The following is a description of a gene set: Genes up-regulated in CD4 T cells activated by anti-CD3 and anti-CD28: IL4 (48h) versus untreated (48h). species: Homo sapiens Human Gene Set: GSE2770_IL4_ACT_VS_ACT_CD4_TCELL_48H_UP Th1 and Th2 cells arise from a common precursor cell in response to triggering through the TCR and cytokine receptors for IL-12 or IL-4. This leads to activation of complex signaling pathways, which are not known in detail. Disturbances in the balance between type 1 and type 2 responses can lead to certain immune-mediated diseases. Thus, it is important to understand how Th1 and Th2 cells are generated. To clarify the mechanisms as to how IL-12 and IL-4 induce Th1 and Th2 differentiation and how TGF-beta can inhibit this process, we have used oligonucleotide arrays to examine the early polarization of Th1 and Th2 cells in the presence and absence of TGF-beta after 0, 2, 6 and 48 hours of polarization. from publication Lund R, Aittokallio T, Nevalainen O, Lahesmaa R (PMID 14607935), and this is the list of marker genes: ATP2A2, PPP4R3B, POLR2E, GAS2L1, LZTFL1, PTPRA, MCRIP2, C3orf70, PALS1, GPR137B, MAN1A2, NDUFS4, GATAD1, SLC25A3 (solute carrier family 25 member 3), LMLN, AKAP11 (A-kinase anchoring protein 11), RNASET2, CUL2, STXBP5, TXNDC11, PTPN11, LEPROTL1, WASHC5, ACTL10, DIPK2A, MBOAT1, MAPK9, PDE8B, GPD2, FNIP2, PPFIBP2, NCOA7, ALS2, PML, GLCE, RPL24, SLC25A24, RAC1, LARP1, CCNYL1, RPP25, XBP1, PLPP6, COX6A1, OMD, UQCRC2, ARHGAP21, TEX30, SDC3, ITGA8, ACVRL1, DSEL, ABI2, ACO2, PDLIM7, HLA-E, C12orf75, SREK1, CMC1, CISD3, MEIS2, RIMOC1, SLC7A8, PRELID2, CYFIP2, CCDC158, TMEM39A, ACTN1, UQCC1, WDFY4, RNF4, GOT2, NDUFAF8, TFB2M, HSP90B1, GDF5, MRPL15, ARHGAP22, GLIPR1L1, CCR1 (C-C motif chemokine receptor 1), RTCB, GOSR1, FHIP1B, TOR1B, SLC8B1, HADH, SEPSECS, STX2, SEC63, CANX, LRRC1, CYP8B1, GMFB, FUNDC1, IARS1, MSC, ITPRIPL2, SLC1A4, AFF1, CERS5, MATN4, ALDOC, UQCRB, RIMKLA, RNF217, METTL6, RPRD1B, MRPS31, MET, ZDHHC21, FARP2, MST1, PHKA2, PPP2R2A, MEF2A, PDCD6 (programmed cell death 6), ATG16L2, ERP44, CD81, FAM162A, DDX18, PLCE1, ILDR1 (immunoglobulin like domain containing receptor 1), MTMR2, KIF2A, LGALSL, AKR1A1, HNRNPLL, RNF157, MAS1, ITFG1, TNFAIP2, SGCB, WDR26, KCNE5, PPP2R3C, NKRF, VPS37C, SYNRG, DNMBP, BMI1, FGF13, CYB5A, NAA16, AGPAT5, HAVCR1, CNIH4, CCNH, ABCE1, CPNE8, NCBP2, DNTTIP2, ZFP36L1, EIF3I, MTERF3, FXYD5, SSR3, MINDY3, DTNBP1, TRIB1, CREB3L2, ORMDL2, APIP, MEX3B, C9orf72, TTC39C, GTF2E2 (general transcription factor IIE subunit 2, NCBI Gene Id 2961), PDGFA, UBE2N, CLPP, TFAP4, GRHL3, ITGA5, SLC4A7 (NCBI Gene Id 9497), HTRA1, ZNG1B, PRDX4, MTMR10, MPZL2, PIK3CB, EPM2A, UCN, FKRP, KCNS2, UMPS, HPS3, DTX4, JPT2, PTDSS1, NDUFS3, ACTG1, SH3PXD2B, REPIN1, MRPL46, PIGF, ARPC2, EIF2S2, KCTD14, MOAP1